The following is a description of a gene set: Human Gene Set: HP_ENLARGEMENT_OF_THE_COSTOCHONDRAL_JUNCTION Enlargement of the costochondral junction Abnormally increased size of the costochondral junctions, which are located between the distal part of the ribs and the costal cartilages, which are bars of hyaline cartilage that connect the ribs to the sternum. studied in species Homo sapiens, and this is the list of marker genes: SLC34A3, DYM, NOG, PRKG2, SBDS, SRP54 (NCBI Gene Id 6729), DNAJC21, CYP2R1, CYP27B1, PHEX